Given this list of marker genes SELENOS, SYVN1, VCP, AMFR, HM13, RNF139, SEL1L, DERL1, here is a description of the gene set: species: Homo sapiens Human Gene Set: GOCC_DERLIN_1_RETROTRANSLOCATION_COMPLEX A protein complex that functions in the retrotranslocation step of ERAD (ER-associated protein degradation), and includes at its core Derlin-1 oligomers forming a retrotranslocation channel.